The following is a description of a gene set: The assembly or remodeling of chromatin composed of DNA complexed with histones, other associated proteins, and sometimes RNA. Human Gene Set: GOBP_CHROMATIN_ORGANIZATION species: Homo sapiens, and this is the list of marker genes: KAT14, HCFC1, BCL7B, HMG20B, MSL3, TUT7, H3-4, DPF2, SYCP1, TCF7L1, PRMT5, H3C2, CDKN1C, DAPK3, BRPF1, NAP1L5, DNAJC2, SUV39H2, PCNA, TADA2A, CHD5, NCOA3, TOX, TDRD12, TLE6, SMYD2, ZNF827, TP53, SETBP1, TET2, ZZZ3, HIPK2, SETDB1, SETMAR, PKN1, SMARCA5, LMNB1, USP3, DAXX, PRIMPOL, MSH6, SIN3A, MYC, HNRNPC, FGF2, MIER1, PER2, GLYR1, SPTY2D1, HDAC10, LHX2, FBLL1, CENPI, ABRAXAS1, SLFN11, H3C12, JMJD1C, RELA, ACTR6, GLMN, MECP2, TP53BP1, SGF29, KANSL1, MCM3AP, H2AZ2, APP, INO80B, SNAI1, TBL1XR1, ALKBH4, SPIN1, TSPY9, ARID1A, BEND3, NAA60, PRKDC, ATF7IP, NAP1L3, H1-6, PML, SMARCE1, TRIP12, SETSIP, IER3IP1, H2BC3, METTL23, H3C1, RNF40, UBR5, SAMD1, H2BC21, CTCF, DTX3L (NCBI Gene Id 151636), H4C16 (H4 histone 16), USP15, FAM50A, SIRT1, H2AJ, ZNF91, BUD23 (BUD23 rRNA methyltransferase and ribosome maturation factor), MYD88, H2BC7 (H2B clustered histone 7), ATG5, KDM3B (lysine demethylase 3B), VRK1, CTR9, MORC4, ATAD2, TSPYL2, PSME4, BPTF, CENPW, C17orf49, BCL6, PAXIP1, TOP1, SMARCAD1, H4C15, PHC1, MBD2, H2BC1, HDAC6, RYBP, NEAT1, PRDM9, H2BC13, DPF3, BAZ1B, TET3, SMCHD1, H3C14, HNRNPU, H1-4, WBP2, SPHK2, TRMT112, SF3B1, SUV39H1, MEN1, FBL, SPEN, WT1, MEAF6, RLF, H3C15 (H3 clustered histone 15), NBN, RBL2, HNRNPK, SELENOF, MORC1, UHRF1, KAT7, GTF3C4, ATM, USP51, C19orf84, YY1, HMGB1, BRCA2, YTHDC1, KDM5A, H4C12, ARID2, H2AC1, TRIM37, NUDT5, MBD3L1, TNP1, KMT2E, CREBZF, MORF4L2, AEBP2, SLF2 (SMC5-SMC6 complex localization factor 2), RPS6KA5, ZNFX1, RCCD1, RUVBL1, JPX, SETD1B, ZNF462, MRGBP, KDM4F, RBBP7, BRCC3, CBX1, TAL1, H4C3, NPM3, M1AP, DIRAS3, BAG6, PTENP1-AS, SMARCC1, PHB1, CENPN, DNMT3A, SETD3, GATAD2A, H2AL3, H4C4, GSK3A, EGR1, H2AC6, BRD7, RBM15, MSL1, BABAM1, TAF1, MTF2, MBD3L5, HDAC1, BANP, PPHLN1, ING3, H4C5, MBD3L3, SETD2, CBX5, DEK, TRIM28, EHMT2, RNF8, TSPY3, SUPT5H, SMYD5, NCOA1 (NCBI Gene Id 8648), EP400, RRP8, HMG20A, RCOR1, PHF21A, DNMT3L, USP16, SET, KDM4D, RERE, INO80E, NCOR1, MBD3L4, BRD4, RLIM, BRCA1, PAX7, SMARCD1, ASZ1, PIWIL1, TEX19, TTLL12, SIRT6, GATAD2B, SETD1A, BCORL1, UBE2B, LOXL2, BARD1, CCER1, HMGN1, KDM5B, PHF2, H2AB1, H2BC4, VPS72, DMAP1, PRKCB (protein kinase C beta), EZHIP, NIPBL, H2BC11, NAP1L1, YEATS4, PRMT9, EP300, SAMD7, PCBP2, KDM5D, L3MBTL1, HDAC4, MDC1, OGG1, HPF1, AXIN1, TDRD1, THAP7, FOXP3, NSD3, CHD2, KDM4A, RNF168, TRRAP, SMARCB1, CHD8, CBX8, CHD1L, PBRM1, PKM, ASXL1, PWP1, APBB1, APOBEC2, CREBBP, H2AC15, TFAP2C, NFKBIZ, BCOR, H3C4 (NCBI Gene Id 8351), ZNF445, SRPK1, KAT2B, HDGFL1, H2AC19, MLLT3 (MLLT3 super elongation complex subunit), MBD3L2, TONSL, ARB2A, PRDM5, PRMT6 (protein arginine methyltransferase 6), H2AC20, KMT2B, WAC, APOBEC3H, MLLT6, MBD1, H3C10, KDM7A, ZNHIT1, RSF1, ASH1L, NFE2, ARID4A, CENPP, HELLS (helicase, lymphoid specific), RBM15B, PRKAA1, RB1, ARB2BP, PRDM16, CDY1, FKBP6, ING2, GPX1 (glutathione peroxidase 1), SART3, DDX21, DCAF1, H3-3B, RNF20, CABIN1, SMARCD2, SPIN2A, PCID2, HLTF, H3C7, DDX23, MAP3K7, H4C8, H2AC21, HIRIP3, NSD1, GTF2B, CDY1B, CHAF1A, GRWD1, TSPY10, KDM5C, CBX7, HDGFL2, SOX1, RING1, ASIP, ZNF618, H2BC10, TFPT, NR5A2, NCAPG2, KMT5A (lysine methyltransferase 5A), H2AC7, KDM6B, PRKAA2, AURKA, HIRA, MIR29B1, INO80C, KAT6B, APOBEC3G, TDG, CHD6, MACROH2A1, ENY2, H1-1, SCMH1, PAK1, EHMT1, H1-0, CGGBP1, HDGF, SIRT7, TAF10, ALKBH1, KMT2C, HDAC8, C6orf89, SPIN2B, BRD2, H2AC4, IRF4, UBR2, BRD9, EYA2, ATAD2B, LRIF1, INO80, TLK2, PRM1, SOX15, PHF13, OIP5, TAF1L, BRD3, MYOCD, ZCWPW1, L3MBTL2, MECOM, BAHD1, TGM2, IGF2, NAP1L2, MKI67, GFI1B, NAP1L4, PHF8, HAT1, MTHFR, BMI1, SOX9, MOV10L1, CHD1, ATR, ZMPSTE24, SMARCA4, N6AMT1, PCGF2, BAZ1A, PWWP2B, RIOX2, CBX4, CTCFL, JDP2, PADI6 (peptidyl arginine deiminase 6), ZNF274, SUPT6H, RCBTB1, NFRKB, MOV10, H2BC9, CDAN1, EID3, TASOR, RAD17, H2AC12, UBN2, FAM50B, PYGO1, HDAC7, SNAI2, TSPYL6 (NCBI Gene Id 388951), EPC1, SUDS3, RBM14, NPM2, APOBEC3B, SS18L1, RTF1, USP36, H1-5, YEATS2, H4C6, H1-8, MYCN, TSPYL1, TTF1, H2AC25, ZMYND8, BUB1, HDAC9, TDRD3, SDR16C5, NAA50, KAT5, BABAM2, BRPF3, KDM3A, RNF2 (ring finger protein 2), NTMT1, ZNF335, ING4, H4C9, LIN54, ZDBF2, FOXA1, MCM2, RBBP5, PCGF6, SSRP1, FSHR, SATB1, FBXO24, ZBTB1, H2AC17, RAG1, SHPRH, ZBTB7A, CHAF1B, NDN, TSPY1, DDB1, TOP2A, TSPYL4, USP22 (NCBI Gene Id 79397), CDK1, SMARCD3, ACTL6B, SMARCC2, PRDM14, APEX1 (apurinic/apyrimidinic endodeoxyribonuclease 1), ARID4B, HIPK4, TDRD9, HDAC5, JARID2, ANP32E, UTY, SIRT2, H2AZ1, TP63, PHF1, H4C11, NSMCE2 (NCBI Gene Id 286053), PADI4, USP7, PADI2, DMRTC2, JAK2, H2AX, EMSY, LBR, ZNF93, LSM11, FBXO30, ASH2L, DHX9, RUVBL2, ZCWPW2, MIR182, KAT2A, PCGF1, KDM2A, BAZ2A, MTA1, TNP2, PCGF5, AICDA (NCBI Gene Id 57379), PWWP2A, INO80D, EPC2 (enhancer of polycomb homolog 2), CFDP1, H2AP, PARP2, DPPA3, ZNF518A, MBTD1, SPIN4, KDM2B, CENPA, H3C8, RAD21, TSPY8, GATA3, MAEL, MIR29A, TAF6L, HASPIN, RSBN1, SRPK2, H2AC8, NSMCE3, DDX4, ING1, CARM1, MPHOSPH8, CASC11, MORC2, TUT4 (NCBI Gene Id 23318), KLF2, TPR, LMNB2, H4C7, MIR29C, SMC6, BANF1, MTA2, MMS22L, DOT1L, ACTR5, ACTR8, CIZ1, APLF, ACTL6A, H2AB3, HJURP, MEG3 (maternally expressed 3), ERCC6, DDX11, KDM4C, SOX2, FOXA3, TAF9, PIWIL4, MALAT1, EZH1, TADA2B, TSSK6, UVSSA, MSL2, ATXN7L3, MTA3, MORF4L1, NCAPD3, NFAT5, SPIN3, EZH2, SMYD1, APOBEC1, USP21, HMGA2, TET1, PRDM6, APOBEC3A, PHF19, ANP32B, GATAD1, HP1BP3, SATB2, BCL7C, CDY2B, CHRAC1, MRE11, POLE3, ZMYND11, EOMES, TBR1, RIOX1, L3MBTL3, TRIM27, MACROH2A2, FOXA2, KMT2A, WDR5 (NCBI Gene Id 11091), KDM4B, CHEK1, SUZ12, IWS1, EYA3, TDRD5, HDAC11, L3MBTL4, UBN1, H2BC17, H2AC18, FAM47E, CBX2, PIH1D1, NUCKS1, DPF1, SPI1, TSPYL5, HMGN2, APOBEC3C, ESR1, PRDM8, GPX4, NSMCE1, KANSL2, CHTOP, PRMT1, MYBBP1A, RHNO1, KMT2D, SFPQ, MIS18A, TSPY4, CHD7, TAF3, PRMT2, H1-7, KDM6A, CXXC1, RIF1, PTMA, STK38, HMGB2, KDM1B, PWWP3A, NASP, CDK2, PRDM13, HUWE1, UHRF2, H2BC6, PRKCA, PSIP1, EED, RAD50, FMR1, BRD8, PCGF3, SAFB, BICRAL, SETD4, PIWIL2, FIRRE, REST, RBL1, HR, MYO1C, H2AC11, H3C3, NPM1, UBE2A, EYA4, RPA1, JADE2, RBBP4, KDM4E, H3-3A, H3C6, CHD3, H4C13, KDM1A, H4C2, H1-2, STPG4, HDAC2, TLK1, METTL3, EYA1 (EYA transcriptional coactivator and phosphatase 1), TEX15, H1-9P, ASF1B, BTBD18, KAT6A, DPY30, KPNA7, PHF14, KDM8 (lysine demethylase 8), PIK3CA, CCDC38, NRDE2, H2BC14, SMC5, MOS, BAZ2B, NAP1L6P, CDKN2B-AS1, CDYL, FBXL19, ASF1A (anti-silencing function 1A histone chaperone), SMYD3, PRMT8, MSL3B, CBX3, CHD9, H1-3, NSD2, ARID1B, KMT5B, HMGA1, ZNF304, BRDT, BICRA, JADE1, METTL4 (NCBI Gene Id 64863), OGT, CHD4, CENPV, PPM1D, PHF20, DNMT1, HCFC2, VCX, HDAC3, H2AC16, MBD3, SMARCA2, ZNF518B, SMARCA1, HMGN3 (NCBI Gene Id 9324), IFI16, ZFP92, PHF10, NSMCE4A, CDY2A, PRDM2, SKP1, RAG2, SLF1, H3C11, TADA3, SFMBT1, SETDB2, ITGB3BP, CECR2 (NCBI Gene Id 27443), SYCP3, TAF7, NAA40, PRMT7, BCL7A, MYSM1, CDK9, KMT5C, COPRS, EPOP, DYRK1A, H1-10, TASOR2, UIMC1, LMNA, HMGN5, RESF1, NR3C1, PARTICL, ATF2, IKZF1, UTP3, MBD3L2B, PRDM7, APOBEC3F, BRD1, SETD7, MORC3, SPOCD1, RPS6KA4, DCAF13, PRMT3, SUPT4H1, PER1, CLOCK, KAT8, XIST, ING5, NOC2L, JMJD6, DNAJC9, RAD54L2, USP49, H2AC13, ZFP57, HTATSF1, TSPY2, CDYL2, H4C1, TOPBP1, LRWD1 (NCBI Gene Id 222229), ATRX, H2AB2, ACTB, SS18, KANSL3, H4C14, UCHL5, PAX6, CBX6, SRCAP, BAP1, RNF169, H2BC8 (NCBI Gene Id 8339), PARP10, SETD5, H3C13, MCRS1, SUPT16H, HMGN4, H2BC15